Given this list of marker genes Dpyd, Nt5c, Tyms, Nme3, Upp1, Nt5m, Nt5c3, Shmt1, Tymp, Upp2, Upb1, Dhfr, Nme2, Cda, Dpys, Nme1 (NCBI Gene Id 18102), Dctd, Dut, Shmt2, here is a description of the gene set: species: Mus musculus The chemical reactions and pathways involving pyrimidine deoxynucleoside monophosphate, a compound consisting of a pyrimidine base linked to a deoxyribose sugar esterified with phosphate on the sugar. Mouse Gene Set: GOBP_PYRIMIDINE_DEOXYRIBONUCLEOSIDE_MONOPHOSPHATE_METABOLIC_PROCESS